Given this list of marker genes AKT1, TLR4, PLP1, IL12A-AS1, ACVRL1, UBAC2, F13A1, ENG, CBS, STAT4, F8, IL23R, CCR1, PROC, JAK2, FAS, SERPINC1, PIGA, GDF2, MTHFR, HLA-B, THBD, PROS1, ERAP1, SMAD4, CD55, C4A, RHAG, MEFV, AGGF1, GNAQ, IFNGR1, IL12A (interleukin 12A), MMACHC, IL10, KCNJ5, KLRC4, F2, PIK3CA, HABP2, here is a description of the gene set: studied in species Homo sapiens Human Gene Set: HP_PULMONARY_EMBOLISM Pulmonary embolism An embolus (that is, an abnormal particle circulating in the blood) located in the pulmonary artery and thereby blocking blood circulation to the lung. Usually the embolus is a blood clot that has developed in an extremity (for instance, a deep venous thrombosis), detached, and traveled through the circulation before becoming trapped in the pulmonary artery.